The following is a description of a gene set: Mouse Gene Set: GOBP_MACROPHAGE_INFLAMMATORY_PROTEIN_1_ALPHA_PRODUCTION The appearance of macrophage inflammatory protein 1 alpha due to biosynthesis or secretion following a cellular stimulus, resulting in an increase in its intracellular or extracellular levels. studied in species Mus musculus, and this is the list of marker genes: Trem2, Mcoln2, Trpv4, Mefv, Nod2, Sirpa, Arg2